Given this list of marker genes MFAP2, HMGN1, KDR, BAX, FBN1, BAK1, EFEMP1, here is a description of the gene set: The process, occurring after embryonic development, by which the anatomical structures of the eye are generated and organized. The eye is the organ of sight. Human Gene Set: GOBP_POST_EMBRYONIC_EYE_MORPHOGENESIS studied in species Homo sapiens